The following is a description of a gene set: The directed movement of proteins into an intracellular organelle, across a membrane. Mouse Gene Set: GOBP_PROTEIN_TRANSMEMBRANE_IMPORT_INTO_INTRACELLULAR_ORGANELLE species: Mus musculus, and this is the list of marker genes: Aifm1, Pex10, Timm50 (NCBI Gene Id 66525), Pex5, Chchd4, Timm23, Timm17a, Tomm40l, Pex2, AU015836, Tomm20l, Pex7, Pex16, Pex5l, Timm44, Dnlz, Grpel1, Romo1, Pex14, Tomm40, Pam16, Tomm70a, Pex12, Timm17b, Trim37, Dnajc15, Pex1, Gfer, Usp9x, Pex13, Tomm20, Hspd1, Hspa8, Dnajc19 (DnaJ heat shock protein family (Hsp40) member C19), Tomm7, Grpel2, Pex6, Pex26, Timm21, Lonp2